The following is a description of a gene set: part of: NS1 Mediated Effects on Host Pathways Interferon Synthesis is inhibited. Reactome Pathway: Inhibition of Interferon Synthesis studied in species Homo sapiens, and this is the list of marker genes: NS